Given this list of marker genes MIR3180-5, MIR520B, SAMD4A, MIR601, MIR125B1, MIR210, MIR146B, MIR205, ALKBH3, MIR367, MIR592, EIF2AK3, TDRD7, LARP4, DDX1, MIR1275, DHX36, MIR105-1, MIR3180-3, FBLL1, MIR548P, NUDT21, CAPRIN2, XPO5, CELF4, MIR503, MIR1180, MIR29B2CHG, TRUB2, TAF15, NT5C3B, OGFOD1, MIR1283-1, UHMK1, MIR511, NGRN, EPHA4, TENT5D, BOLL, LARP6, MTPN, RPS14, MIR671, EIF5A, MIR130A, MIR4516, ZNF385A, PABPN1L, GIGYF2, LIMD1, JMJD4, MIR615, MIR516A2, MIR1271, MIR657, EIF4E2, MIR302C, MIR625, MIR548D1, MIR600, PPP1CA, MIR548D2, MIR519E, MIR33B, MIR548X2, MIR944, MIR3074, MIR624, YTHDF3, MIR638, EPRS1, RNASEL, APLP1, MIR3677HG, NAF1, MIR183, MIR938, IGF2BP3, DIO2, MIR451B, MIR483, MIR424, MIR337, PRR16, MIR1178, HRURF, MIR9-2, MIR103B2, MIR1-2, USP16 (ubiquitin specific peptidase 16), MIRLET7C, MIR100, MIR126, MIR323B, MIR767, MIR92B, THRAP3, MIR549A, STAU1, MIR137HG, DDX6, MIR526A2, PRKCH, MIR206, TNRC6C (NCBI Gene Id 57690), MIR517C, PUM1, MIR595, MIR1296, EPB41L5, PNLDC1, MIR889, SMYD5, DAZ4, MIR518A1, MIR23AHG (miR-23a/27a/24-2 cluster host gene), MIRLET7B, MIR660, MIR597, RPS4X, MIR505, MIR1302-4, ABCF1, DDX49 (NCBI Gene Id 54701), MEX3D, MIRLET7BHG, TGFB1, MIR24-2, MIR320A, MIR556, MIR219B, ACE, PRKCA, TNFRSF1B, MALSU1, MIR29B2, DIS3, CPEB1, MIR1260B, TIRAP, PAIP2, MIR520E, MIR532, TRIM71 (tripartite motif containing 71), FOXO3, MIR181D, EIF3B, MIR583, AGO2, MIR147A, HOXB-AS3, MIR3591, MIR152, MIR153-1, MIRLET7A1, MIR361, CNOT8, PRMT1, CNOT1, MIR675, NEURL1, MIR552, ZCCHC13, MIR518E, MIR744, RPS3, MIR302D, MIR766, MIR193A (NCBI Gene Id 406968), MIR500B (microRNA 500b), MIR1251, MIR581, SHFL, HBS1L, MIR342, EIF3C, MIR588, SSB, MIR924, TNRC6A, MIR133B, OTUD6B (OTU deubiquitinase 6B), TENT2, EIF4EBP2, MIR518F, MIR891B, MIR649, MIR652, PRKDC, MIR937, NCBP2, MIR136, MIR26B, MIR133A1HG, MIR28, PPP1R15B (protein phosphatase 1 regulatory subunit 15B), MIR200C, MIR584, MIR147B, MIR5588, RBM4, CD28, MIR127, EIF4H, EIF3E, MIR184, GRB7, CNOT4, ZSWIM8, MIR30A, MIR765, NANOS1, RBM33 (NCBI Gene Id 92454), MIR1224, MIR323A, MIR563, ZC3H18, MIR204, MIR200A, RPS6KA3, COA3, MIR26A1, NPM1, TENT5B, MIR149, MIR496, MIR423, MIR578, MIR329-1, ERBB2, DKC1, SECISBP2, MIR384, MIR655, ITGA2, MIR654, MIR10B, MIR494, MIR103B1, MIR640, MIR942, YBX1, RIPK1, MIR516A1, DICER1, MIR1307, RNH1, NORAD, GEMIN5, MIR519D, TCOF1, GTDC1, MIR145, MSI2, MIR522, CASC3, CPEB4, TP53 (tumor protein p53), EIF3H, RPUSD4, IL6, RPS27L, CPEB3, MIR1265, MIR450B, MIR608, METTL14, MIR130B, MIR181A2, MIR218-2, SHMT1, MIR515-1, MIR539, MIR653, RBM4B, MIR642A, MIR196A1, MIR34B, PURB, TNF, MIR1226, MIR557, PIWIL2, MIR650, MIR605, MIR1181, ATXN2, TRAF5, MIR613, CARHSP1, GDNF, TARDBP, BMP4, LSM1, EIF4EBP1, MIR590, MIR18B, ZAR1L, DIS3L2, MSI1, UNK, PAN3, MRPS27, PUM2, MIR885, MIR3619, RPL10, MIR486-1, MIR892B, MIR135A1, MIR135B, MIR564, ADAR, MIR607, MIR181C, IREB2, AJUBA, RGS2 (regulator of G protein signaling 2), MIR122, MIR135A2, HNRNPA0, MIR609, ZFP36, EIF2A, ZAR1, MIR517A, MIR575 (microRNA 575), MIR517B, MIR643, MIR132, PAIP2B, MIR518B, MIR432, PKP3, MIR181A1, MTG1, MIR29C, PARP16, IFRD2, APOBEC1, MIR320E, MIR320C2, CALCR, MIR192, MIR15A, NAT10, MIR429, MIR203B, SELENOT, MIR632, PYM1, EIF2B5, PPP1R15A, EIF5A2, UPF1, ZNF598, AIRE, MIR506 (NCBI Gene Id 574511), YBX2, MIR1185-1, MIR939, MIR551B, ELP1, LIN28B, PRG3, MIR550A3, MIR656, MIR1197, FASTKD1, MIR454, DNAJC3, PIWIL3, PLD1 (NCBI Gene Id 5337), RC3H1, SCGB1A1, MIR7-3, MOV10L1, ZC3H12A, TSNAX, MIR218-1, LL22NC03-63E9.3, RC3H2, MAP3K20, TENT4B, ALKBH1, KRT17, MIR9-1, MIR134, MIR3142HG, MIR422A, PER1, ETF1, CNOT7 (CCR4-NOT transcription complex subunit 7), MIR873, EIF2AK4 (NCBI Gene Id 440275), MIR4691, LARP1B, MIR3179-2, MIR30C2, MIR580 (NCBI Gene Id 693165), RBM46, SH3BGRL, MIR802, YBX3, GTSF1, IGFBP5, MIR106A, MIR599, MIR548AA2, PHAX, MIR27B, PIWIL1, HNRNPC, CACNA2D1-AS1, PDE12, MIR365A, RNF139, MIR593, MIR139, MIR7-1, MEIOC, MIRLET7D, WTIP, MIR576, MIR520C, PATL2, MIR516B2, MIR374A, UPF3B, MIR30B, PABPC4, ATG14, MTG2, MIR487A, EIF2S1, AXIN2, EIF2AK2, MIR137, TIAL1, MIR577, MIR128-1, MIR663B, YTHDF1, MIR519A1, MIR124-1, MIR548M, HABP4, MIR30D, NIBAN1, MIR129-1, EIF6, MIR520D, MIR4286, MIR199A2, MIR586, SARS1, MIR339, NICOL1, MIR663A, PML, TRNAU1AP, PABPC1, MIR23A, MIR211, PNPT1 (polyribonucleotide nucleotidyltransferase 1), MIR642B, MIR486-2, TRAP1, ZC3H7A, MIR448, MIR621, MIR324, MTOR, MIR138-2, AGO1, MIR346, STAT3, MIR32, METTL3, THBS1, MIR9-3, MIR558, MIR217, MIR1302-5, MIR922, SEPSECS, NEAT1, EEF2K, ENDOU, MIR519B (microRNA 519b), MIR376B, MIR2355, MIR143 (NCBI Gene Id 406935), BZW1, MIR484, RMND1, MIR375, DAZ3, ANGEL2, MIR569, TRAF2, SHMT2, EIF5B, RACK1, MIR101-1, E2F1 (NCBI Gene Id 1869), AKT1, NCK1, ELOC, PARN, EIF4EBP3, SERP1, LRPPRC, MIR1306, KLHL25, UPF3A, VIM, MIR550A2, MIR769, MIR648, MIR215, EIF4E1B, CSNK2A1, UCN, HNRNPD, MIR382, TENT5C, PKP1, DHFR, MIRLET7F2, FTO, MIR1207, BTG2, MIR891A, MIR665, ZC3H10, DNM3OS, MIR376C, MIR708, MIR328, MIR518D, MIR338, MIR541, MIR154, MIR23B, MIR98, XIST, MIR374C, FMR1 (fragile X messenger ribonucleoprotein 1), DAZ2, MIR936, MIR548C, MIR582, MIR490 (microRNA 490), MIR320C1, MIR554, MIR633, MIR450A2, ELAVL1, PTCD3, LARP4B, MIR500A, MIR567, MIR17, MIR299, MOV10 (NCBI Gene Id 57723), EIF2AK1, MIR301A, MIR485, MIR450A1, MIR372, MIR764, MIR190A, MIR383, EIF5, MIR497, MIR10A, TNRC6B (NCBI Gene Id 23112), CCL5, METTL8, ARID5A, ZCCHC17, ABCE1, PKM (pyruvate kinase M1/2), LIN28A, MIR760, DCP1B, ZNF706, RPL26, MIR1225, RPS6KB1, MIR3065, PASK, CNBP, LSM14B, MIR1283-2, MIR770, MIR572, MIR320D2, MIURF (NCBI Gene Id 127898561), MIR155HG, MIR4632, NANOS3, MIR1302-2, RBM24, ENSG00000293600, MIR491, MIR133A1, ZFP36L1, MIR1912, AARS1, BANK1, MRPL13, MIR29B1, CAV1, MIR214, MIR138-1, PURA, MIR99A, PADI6, SPOUT1, MIR30E, MIR498, TBRG4, SYNCRIP, MIR216B, MYD88, CARMN, MIR874, MIR106B, NSUN5, MIR935, MIR514A1, MIR340 (microRNA 340), MIR331, MIR1227, TIFAB, MIR19B1, TACO1, MIR661, MIR301B, MIR3661, NCK2, MIR550B2, SENP1, RBM8A, VIP, MIR1298, MIR103A1, OIP5-AS1, DNAJC1, RPL38, MIR455 (microRNA 455), MIR544A, TRUB1, NMNAT2, C8orf88, ZMPSTE24, PELO, CNOT2, MALAT1, MIR345, APEX1, MIR34A, MIR363, MIR223 (NCBI Gene Id 407008), ANG, NCBP3, MIR101-2, CIRBP, IGF2BP2, MIR105-2, EIF1B, MIR499A, ROCK2, MIR3180-2, MIR155 (NCBI Gene Id 406947), YTHDF2, DCPS, MIR876, MIR302A, MIR199A1, MIR1908, FASTKD3, MIR24-1, DHX29, FASTK, ATF4, DCP1A, METTL16, GCNT2, MIR523, MIR190B, MIR548AZ, MIR877, MIR194-1, DXO, MIR27A, AGO3, RPUSD3, IMPACT, MIR527, MIR425, TENT5A, PINK1, WT1, MIR329-2, CLP1, MIR618, MIR3180-4, MIR550A1, ZC3H14, DCP2, MIR148B (NCBI Gene Id 442892), MIR188, DAPK3, DAZ1, ELP5, MLH1, TPR, MIR216A, MKNK1, CNOT6L, BCL3, GCN1, POLR2G, TSFM, MIR144, SAMD4B, MIR451A, RPS9, B3GNTL1, MIR181B2, RBM47 (NCBI Gene Id 54502), MIR758, MIRLET7G, MIR18A, CSDC2, MIR411, TSN (NCBI Gene Id 7247), MIR141, CPEB2, MIR371A, OGT, SMAD5-AS1, MIR521-1, CACNG7, KHSRP, MIR224, EIF4G2, ZCCHC4, ACO1, NGDN, PIAS4, MIR376A2, LINC-ROR, MIR142, MIR186, MIR148A, HELZ2, EIF4E, MAGOH, NSUN2, PLEKHN1 (pleckstrin homology domain containing N1), MIR1-1, EIF2B2, RBMS3, ZFP36L2, PA2G4, FXR2 (NCBI Gene Id 9513), TENT4A, MIR96, APP, KBTBD8, MIR300, MIR330, MIR493, MIR492, EIF4ENIF1, RAN (NCBI Gene Id 87046), RIDA, IGF2BP1, DHX9, POLDIP3, MIR628 (microRNA 628), MIR1287, TUSC8, MIR30C1, MIR34BHG, MIR518A2, LSM14A, MIR370 (NCBI Gene Id 442915), MIR574, MIR934, MIR449B, MIR140, MIR200B, MIR659, MIR1185-2, ZNF540, DDX3X, MIR551A, MIR26A2, GSPT1, MIR221, KRT13, FUS, MIR3148, MAPKAPK5, MIR1255B1, MIR195, HSPB1, MIR3120, PUM3, MIR4500, MIR612, MIR433, HNRNPU, IKBKE, EIF4A3, RPL5, ELAVL4, MIRLET7I, MIR516B1, MIR320B1, MIR125A, CTIF (NCBI Gene Id 9811), EIF4A2, MIR151A, GAPDH, MIR520G, MIR20A, MIR17HG, MIR196A2, MEG3, RCC1L, MIR644A (microRNA 644a), MIR487B, MIR194-2, TUT4, MIR489, PCIF1, MIR124-2, MIRLET7A3, MIR320B2, SPACA6-AS1, MIR222, MIR182, HOTTIP, MIR1249, MIR93 (NCBI Gene Id 407050), EIF1, MIR185, ALKBH5, MIR296 (NCBI Gene Id 407022), GUF1, EIF2B4, MIR34C, EEFSEC, MIR302E, MIR499B, MIR3909, MIR129-2, ELOB, RARA, GZMB, MIR326, ILF3, MIR3184, TRDMT1 (tRNA aspartic acid methyltransferase 1), METTL5, MIR488, MIR676, MIR1253, MIR369, MIR302B, FASTKD5, MIR518C, TUT7, FOCAD, MIR202, MIR208B, AKT2, MIRLET7E, PAN2, EIF4E3, MIR191, MIR19B2, MIR525, MIR651, MIR208A, MIR636, RBM10, MIR20B, MIR125B2, MIR553, MIR198, MIR519C, MIR103A2, DDX25, CNOT9, MIR449C, MIR362, MIRLET7F1, MIR196B, MIR616 (microRNA 616), MIR412, RPS6KB2, MIR887, MIR377, MIR181B1, MIR9-2HG, MIR1277, MIR199B, MIR662, MIR504, SLC11A1, SESN2, MIR34AHG, PARP9, MIR133A2, MIR92A1, MIR29A, MIR320D1, MIR626, MIR373, MIR7-2, DGCR8, MIR548AJ2, MAEL, TOB1, MIR940, ELP2, QKI, MIR573, MIR452, XRN1, DAPL1, CALR, MIR410, ROCK1, MIR543, METAP2, MIR33A, MIR509-1, MIR631, MIR548H4, PATL1, FXR1 (FMR1 autosomal homolog 1), RBM38, MIR409, MIR6869, MIR99B, MIR219A2, CNOT6, TNKS1BP1, MIR16-1, MIR920, DAPK1, TRMT10C, MIR501, MIR335, MIR203A, MIR521-2, MPV17L2, HOXA10-AS, TARBP2, UQCC2, MIR542, ELP3, MIR378A, MIR3173, CDC37, MIR495, MIR22, PIWIL4, MIR524, CYFIP1, TIA1, FBXO4, MIR19A, MIR526B, MIR1246, ZC3H7B, MIR381, DAP, NCBP1, MIR1237, MTIF2, LARP1, MIR639, MIR548H3, DHFRP1, CNOT10, MIR187, MIR4686, ELP6, SRP9, FAM76B, TRAF3IP2, MIR298, EIF4B, CAPRIN1, BZW2, MATR3, MIR6086, EIF4G1, MIR92A2, MIR150, FASTKD2, MIRLET7A2 (microRNA let-7a-2), ELP4, BARHL2, MIR1827, MIR1183, MIR219A1, NANOS2, A1CF, NOCT, CNOT11, NOLC1, HELZ (NCBI Gene Id 9931), MIR379, C1QBP (NCBI Gene Id 708), MIR519A2, MAPK14, BCDIN3D, MIR520H, KHDRBS1, MIR197, MKNK2, MIR548A3, MIR508, SARNP (SAP domain containing ribonucleoprotein), EIF3K, EIF5AL1, MIR520F (NCBI Gene Id 574464), MIR124-3, RPS6KA1, METAP1, MIR711, EEF2, METTL18, MIR668, MIR31 (NCBI Gene Id 407035), MIR611, MIR374B, MIR146A, EIF4G3, ZC3H12D, MIR761, SRSF1, SCRIB, NRDE2, TYMS, MIR550B1, RBM3, MIR589, METTL1 (methyltransferase 1, tRNA methylguanosine), NSUN3, DND1, DUS3L, MIR3529, MIR526A1, PLXNB2, INPP5E, MIR875, AGO4, MIR25, MIR1208, PUS7, MIR604, PCBP4, MIR520A, CDK5RAP1, CSDE1, PTENP1-AS, MIF4GD, WFS1, ENC1, MIR212, PRKCD, DAZL, MIR15B, MIR562, MIR21, MIR193B, SERBP1, MAPKAPK2, MIR16-2, CNOT3, RPL13A, YTHDC1 (NCBI Gene Id 91746), MIR107, MIR449A, MIR502, NCL, HHEX, MIR548H2, CELF1, PAIP1, here is a description of the gene set: species: Homo sapiens Any process that modulates the frequency, rate or extent of gene expression after the production of an RNA transcript. Human Gene Set: GOBP_POST_TRANSCRIPTIONAL_REGULATION_OF_GENE_EXPRESSION